The following is a description of a gene set: Genes up-regulated in comparison of lineage negative versus neutrophils. species: Homo sapiens Each fraction of mouse hematopoietic cells was purified by cell sorting from bone marrow of 8-week-old C57BL/6 mice, and its gene expression was analyzed. Human Gene Set: GSE27786_LIN_NEG_VS_NEUTROPHIL_UP from publication Konuma T, Nakamura S, Miyagi S, Negishi M, Chiba T, Oguro H, Yuan J, Mochizuki-Kashio M, Ichikawa H, Miyoshi H, Vidal M, Iwama A (PMID 21540074), and this is the list of marker genes: RSRC1, ACSL5, PPP1R36, POU5F2, RCC1L, METTL16, POLR1B, DMAC2L, PIAS2, ZPR1, DDX19A, PSMF1, BUD23, RARS1, PHF10, DIO2, DIPK1A, PLCG1, RCL1, REXO4, OCSTAMP, BFSP2, IMMP2L, TAMALIN, PML, SIAE, CBR4, ANGPTL4, C1orf174, YWHAQ, TMEM177, SPATS2L, SUZ12, TXN2, TARS2, SARS1, MRPS25, CFAP418, TRMT10B, RRAD, CDIP1, MCM9, GTF2F2, TUT4, MDC1, PATZ1, NRXN1, RAD51AP1, RBM45, GAS8, AMACR (NCBI Gene Id 23600), TBRG1, BMAL1, HNRNPC, NPRL3, MAGT1, SHMT1, MTM1, SNRNP200, SLC35D1, SREBF1, RTTN, RBBP4, LDHB, MIGA1 (NCBI Gene Id 374986), EHHADH, CRIP2, ARL4C (ADP ribosylation factor like GTPase 4C), WDR55, PLBD2, TRMT112, DAP3, ARMCX4, PTAR1, DPY19L4, TEX2, ELN, LSM14B, DNAJA4, PAQR8, ANKH, NDUFB2, ADARB2, GNPNAT1, BAX, DHX16, TMEM178A (NCBI Gene Id 130733), ACACA, B3GNT8, AK4, NT5M, IFT74, COQ9, BOP1, SETDB2, H1-0, GRPEL2 (NCBI Gene Id 134266), DAAM1, NCBP1, RPS11 (NCBI Gene Id 6205), DMKN, RUSF1, TRAPPC12, EME2, P2RY10, ZNF569, BRMS1L, CTDNEP1, PGGT1B, SCAF4, CD72, C10orf88, RLIG1, FOXO1 (forkhead box O1), LRRC59, NDUFAB1, ZNF213, SLC25A1, RSL24D1, PNN, MRPL34, VPS50, NDUFAF5, AFG3L2, PCBP2, SLC43A3, SEPTIN8, RPL13A (ribosomal protein L13a), NOMO1, IMP4, NSMCE4A, LCMT2 (leucine carboxyl methyltransferase 2), NSUN5, ORC6, CD79B, LAMB3, RPS6, FARSA, GPR174, DBI, TTC19, UCK1, DRG2, PLEKHA6, CHD9 (NCBI Gene Id 80205), FOXK2, TERT, NKG7, SCFD2, TMTC4, VCPKMT, TRIM45, SELENOS, DIAPH3, TEX13B, STYX, KLRC1, NFYA, MIER2, LRRC14, LONP1, PECR, SMPD4, RRP1, ZSCAN22, HDAC10, ALS2, ABCB10, MFHAS1, THYN1, CBX6, SETDB1, TMEM191C, BRF1 (BRF1 RNA polymerase III transcription initiation factor subunit), ELK3, RPP25L, FAM171A1, GNB1L, COA6, PDHB, OTULIN, ADI1, NOP2, CEBPZ, POT1, P4HB, RPLP2, CXXC5, AIRN, FIRRM, LLGL1, SRFBP1, FAM133B (family with sequence similarity 133 member B), ELP5, SLC22A5 (NCBI Gene Id 6584), BORCS5, ENPP4, BST2, NUDT12